Given this list of marker genes Il2, Hpx, 6030468B19Rik, Il23a, Dennd1b, H2-D1, H2-M3, Ulbp1, Hmces, Fcer1g, Mad2l2, Nod2, Kmt5c, 2410137M14Rik, Tnfsf13, Ripk2, Jak2, Traf2, Il1r1, Cd81, H2-T24 (histocompatibility 2, T region locus 24, NCBI Gene Id 15042), H2-M5, Tfrc, Arid5a, Tyk2, Sirt1, Cd55b, Slc22a13, Eif2ak4, H2-M10.3, Zp3, Sash3, Brd4, H60c, Pvr, Prkcq, Azgp1, C3, Tbx21, Il1b, Nlrp3, Il12a, Mif, Pagr1a, Nlrp10, H2-M9, Ywhag, Raet1d, Prkcz, Brd2, Akirin2, H2-Q7, H2-T22, H2-M10.5, Nfkbiz, Cd44, Zbtb1, Fcer2a, H2-Q10, Mlh1, Pycard, H2-Q2, Raet1e, Foxp3 (NCBI Gene Id 20371), H2-M2, Slamf1, Fzd5, Ccr2, H60b, H2-T13, Tnf (NCBI Gene Id 21926), Il18, H2-DMa, Tgfb1, Cd24a, P2rx7, Stx7, Hspa8, Tap2, H2-Ea (NCBI Gene Id 14968), Ighg2b, Pla2g4a, Exosc3, Pnp, Trem2, H2-T3, H2-K1, H2-Q1, H2-Q6, Fcgr3, Paxip1, Clcf1, H2-T23, Il12rb1, Malt1, Ep300, Card9, H2-M1, Fcgr1 (Fc receptor, IgG, high affinity I), Il12b, Ighg1, H2-M10.2, H2-M11, H2-M10.4, Stat6, Clec4n, Xcl1 (NCBI Gene Id 98422), Tnfsf4, Gimap3, Slc11a1, Cd40, Pms2, Btk, Map3k7, Shld1, Tnfsf13b, Shld3, H2-M10.6, Clec7a, H2-T15, Exosc6, Atad5, Mr1, B2m, Ada, H2-Q4, Cd4, Gata3 (GATA binding protein 3), Cd1d1 (NCBI Gene Id 99710), Il18r1, Mir301, Gimap5, H2-T5, Hspd1, Traf6, Il23r, Rsad2, Lta, Cd28, Opa1, Nfkbid, Kmt5b, Cd226, Il4, Ifng, Cd1d2, Rif1, Fcer1a, Msh2, Fbxo38, Tnfrsf13c, Il27ra, Nsd2, Cd55, Nectin2, Prkaa1, Trp53bp1, Shld2, Il6, Cyrib, Cd74, H2-M10.1, Ptprc, Fadd, Klhl22, Mir326, Skap1, here is a description of the gene set: Mouse Gene Set: GOBP_POSITIVE_REGULATION_OF_ADAPTIVE_IMMUNE_RESPONSE Any process that activates or increases the frequency, rate, or extent of an adaptive immune response. studied in species Mus musculus